Given this list of marker genes KLKB1, SLC12A2, THBD, ANXA2, MDK, RGMA, PTEN, AJAP1, PLAT, MIR1298, RTCA, CASK, FAP, F12, UBASH3B, CLASP1, PDGFB, USF1, CEACAM1, EXTL3, KRT1, SH2B3, CPB2, ADTRP, MIR200B, MIR34A, F2, LRIG2, MMRN1, ADAMTS18 (NCBI Gene Id 170692), PLAU, SERPINE2, C1QTNF1, TSPAN8, CD109, PROS1, SPP1, TMX1, INPP5F, ALOX12, APCS, MIR15B, SIGLEC10, SMAD3, SERPINB2, RTN4RL1, FIGNL2, PDGFA, CERS2, GP1BA, TFPI, PTPN6, PRKG1, THBS1, TAFA5 (TAFA chemokine like family member 5), KIAA0319, PDGFRA, TNF, GIT1, PF4, SERPINF2, NOS3, KNG1, HRG, PHLDB2, APOH, SERPING1, SERPINE1, VTN, NEO1 (NCBI Gene Id 4756), FGA, FGF2, DSG2, KREMEN1, IL17A, TNR, STAT3 (signal transducer and activator of transcription 3), PTPRS, CD9, REG3A, RTN4R, ALOX5 (NCBI Gene Id 240), PRKCD, EPHA4 (NCBI Gene Id 401031), PLG, PLAUR, FGB, MYOZ1, WNT4, APOE, EDN1, CRK, IL33, PROC, EPPK1 (NCBI Gene Id 83481), WFDC1, FGG, CLASP2, F11, here is a description of the gene set: Any process that stops, prevents or reduces the frequency, rate or extent of response to wounding. Human Gene Set: GOBP_NEGATIVE_REGULATION_OF_RESPONSE_TO_WOUNDING species: Homo sapiens